Given this list of marker genes GFPT2, SFTPD, CLEC2B (NCBI Gene Id 9976), FCN2, LGALS1, CD72, FCN1, THBD, SFTPA1, PRG2, CLEC10A, NCAN, SIGLEC5, CLEC3A, REG1B, APCS, KLRK1, LGALS2, GCKR, CHIT1, LGALS4, CLEC3B, LGALS9, LGALS3, MRC1, CD22, OLR1, SELP, FCER2, ADGRL2, CLC, SELL, KLRC3, FCN3, CD69, ASGR2, ASGR1, here is a description of the gene set: Human Gene Set: MODULE_96 Genes in the cancer module 96. studied in species Homo sapiens